Given this list of marker genes SYNE2, HNRNPDL, LMNA, EMD, SGCD, NAA60, TRPV4, MORC2, LMX1B (NCBI Gene Id 4010), MTMR14, SYNE1, TCAP, FHL1, TMEM43, DNM2, here is a description of the gene set: Abnormality of the upper arm Human Gene Set: HP_ABNORMALITY_OF_THE_UPPER_ARM species: Homo sapiens